The following is a description of a gene set: Any cytoplasm that is part of a axon. Human Gene Set: GOCC_AXON_CYTOPLASM species: Homo sapiens, and this is the list of marker genes: ARL8A, HDAC6, PAFAH1B1, DTNBP1, DST, SNAPIN, DYNLL1, MAP1A, NDEL1, UCHL1, HSPB1 (NCBI Gene Id 3315), AGTPBP1, BLOC1S4, BLOC1S3, SYBU, SPG7, KIF1A, HSBP1, KIF21A, ARL8B, KIF5C, ARMCX3, AP3M2, TMEM108, MGARP, NEFL, KIF1C, FBXW11, KIF1B, AP3D1, KIF4A, SOD1, DYNC1H1, BLOC1S2, TRAK1 (trafficking kinesin protein 1), TRIM46, AP3B1, MAPT, ACTR10, MAPK8IP3, RAB21, AP3M1, OPA1, DLG2, KIF3B, HIF1A, BLOC1S5, AP3S1, AGBL4, KIF5A, SPAST, BLOC1S6, RAB27B, KIF3A, NETO1, KIF5B, RANGAP1, BLOC1S1, ZC3H14, AP3B2, HAP1, AP3S2